Given this list of marker genes Sarm1, Art2b, Nnmt, Nudt12, Nudt17, Parp14, Aox1, Art2a, here is a description of the gene set: The chemical reactions and pathways resulting in the breakdown of nicotinamide adenine dinucleotide (NAD+), a coenzyme that interconverts with its reduced form, NADH, in many redox and catabolic reactions. studied in species Mus musculus Mouse Gene Set: GOBP_NAD_CATABOLIC_PROCESS